Given this list of marker genes PSMB2, PSMD6, HLA-DPB1, PSMD2, PIK3CB, UBE2D1, PSMB7, PSMB6, PRKCQ, MALT1, LCK, UBE2V1, CD3G, TRAC, HLA-DRB3, PSMD1, CD247, HLA-DPA1, PIK3R1, PSMB3, PSMD13, PSMC4, HLA-DQA2, PSMD3, TRAF6, IKBKG, CDC34, CD4, CARD11, HLA-DRB1, PSMA4, HLA-DQB1, PSMC1, PSMD8, HLA-DRA, PSMB5, SKP1, BCL10, NFKB1, HLA-DRB5, MAP3K7, HLA-DRB4, SEM1, FBXW11, PIK3CA, TRBV12-3, ADRM1, CD3D, UBA52, TRAT1, PSMA5, RPS27A, PSMC5, PSMD11, PSMD12, PSMA6, TRAV29DV5, PSMC3, TAB2, PSMA2, NFKBIA, PSMA7, PSMC2, RIPK2, PSMA1, TRAV19, UBC, CD3E, RELA, PSMC6, TRBV7-9, UBE2D2, PSMB1, TRBC1 (NCBI Gene Id 28639), PSMD14, HLA-DQA1, UBB, PSMA3, IKBKB, UBE2N, CHUK, HLA-DQB2 (NCBI Gene Id 3120), PSMD7, PTEN, INPP5D (inositol polyphosphate-5-phosphatase D), BTRC, PSMB4, CUL1, PDPK1, TRAV8-4, PIK3R2, here is a description of the gene set: Reactome Pathway: Downstream TCR signaling species: Homo sapiens Changes in gene expression are required for the T cell to gain full proliferative competence and to produce effector cytokines. Three transcription factors in particular have been found to play a key role in TCR-stimulated changes in gene expression, namely NFkappaB, NFAT and AP-1. A key step in NFkappaB activation is the stimulation and translocation of PRKCQ. The critical element that effects PRKCQ activation is PI3K. PI3K translocates to the plasma membrane by interacting with phospho-tyrosines on CD28 via its two SH2 domains located in p85 subunit (step 24). The p110 subunit of PI3K phosphorylates the inositol ring of PIP2 to generate PIP3 (steps 25). The reverse dephosphorylation process from PIP3 to PIP2 is catalysed by PTEN (step 27). PIP3 may also be dephosphorylated by the phosphatase SHIP to generate PI-3,4-P2 (step 26). PIP3 and PI-3,4-P2 acts as binding sites to the PH domain of PDK1 (step 28) and AKT (step 29). PKB is activated in response to PI3K stimulation by PDK1 (step 30). PDK1 has an essential role in regulating the activation of PRKCQ and recruitment of CBM complex to the immune synapse. PRKCQ is a member of novel class (DAG dependent, Ca++ independent) of PKC and the only member known to translocate to this synapse. Prior to TCR stimulation PRKCQ exists in an inactive closed conformation. TCR signals stimulate PRKCQ (step 31) and release DAG molecules. Subsequently, DAG binds to PRKCQ via the C1 domain and undergoes phosphorylation on tyrosine 90 by LCK to attain an open conformation (step 32). PRKCQ is further phosphorylated by PDK1 on threonine 538 (step 33). This step is critical for PKC activity. CARMA1 translocates to the plasma membrane following the interaction of its SH3 domain with the 'PxxP' motif on PDK1 (step 34). CARMA1 is phosphorylated by PKC-theta on residue S552 (step 35), leading to the oligomerization of CARMA1. This complex acts as a scaffold, recruiting BCL10 to the synapse by interacting with their CARD domains (step 36). BCL10 undergoes phosphorylation mediated by the enzyme RIP2 (step 37). Activated BCL10 then mediates the ubiquitination of IKBKG by recruiting MALT1 and TRAF6. MALT1 binds to BCL10 with its Ig-like domains and undergoes oligomerization (step 38). TRAF6 binds to the oligomerized MALT1 and also undergoes oligomerization (step 39). Oligomerized TRAF6 acts as a ubiquitin-protein ligase, catalyzing auto-K63-linked polyubiquitination (step 40). This K-63 ubiquitinated TRAF6 activates MAP3K7 kinase bound to TAB2 (step 41) and also ubiquitinates IKBKG in the IKK complex (step 44). MAP3K7 undergoes autophosphorylation on residues T184 and T187 and gets activated (step 42). Activated MAP3K7 kinase phosphorylates IKBKB on residues S177 and S181 in the activation loop and activates the IKK kinase activity (step 43). IKBKB phosphorylates the NFKBIA bound to the NFkappaB heterodimer, on residues S19 and S23 (step 45) and directs NFKBIA to 26S proteasome degradation (step 47). The NFkappaB heterodimer with a free NTS sequence finally migrates to the nucleus to regulate gene transcription (step 46). part of: TCR signaling